Given this list of marker genes CSF2RB, SFTPB, SFTPA2, SFTPA1, SFTPD, SFTA3 (NCBI Gene Id 253970), CSF2RA, SFTPC (NCBI Gene Id 6440), here is a description of the gene set: part of: Diseases associated with surfactant metabolism Surfactant catabolism by alveolar macrophages plays a small but critical part in surfactant recycling and metabolism. Upon ligand binding, granulocyte-macrophage colony-stimulating factor receptor (GM-CSFR), a heterodimer of alpha (CSF2RA) and beta (CSF2RB) subunits, initiates a signalling process that not only induces proliferation, differentiation and functional activation of hematopoietic cells but can also determine surfactant uptake into alveolar macrophages and its degradation via clathrin-coated vesicles. Defects in human CSF2RA can cause pulmonary surfactant metabolism dysfunction 4 (SMDP4; MIM:300770, aka congenital pulmonary alveolar proteinosis, (PAP)), a rare lung disorder due to impaired surfactant homeostasis characterised by alveoli filling with floccular material. Cellular responses to the misfolded pro-SFTPC products include ER stress, the activation of reactive oxygen species and autophagy. Excessive lipoprotein accumulation in the alveoli results in a form of respiratory distress syndrome in premature infants (RDS; MIM:267450). species: Homo sapiens Reactome Pathway: Defective CSF2RA causes SMDP4